Given this list of marker genes TIMP3, MCL1, AKT1, BAG1, FAIM, here is a description of the gene set: Human Gene Set: LAU_APOPTOSIS_CDKN2A_DN Genes down-regulated by UV-irradiation in cervical cancer cells after knockdown of CDKN2A. from publication Lau WM, Ho TH, Hui KM (PMID 17369842) species: Homo sapiens p16(INK4A) (p16) has been suggested to be an early biomarker for the detection of cervical cancer. However, its functional role in cervical cancer is not well characterized. In this study, we reported the consistent and significant upregulation of p16 in cervical cancer tissues when compared to both matched non-tumourous tissues of the same patient and normal cervical tissues from non-cancer patients. We have employed p16 small interfering RNA (siRNA) to dissect the role of p16 in cervical carcinogenesis. Although the silencing of p16 was accompanied by the upregulation of p53, p21 and RB in the p16 siRNA-transfected cells, no significant effect on cell cycle progression was observed. When the p16 siRNA-silenced cells were subjected to DNA damage stress including ultraviolet-irradiation and cisplatin treatments, a significantly higher percentage of apoptotic cells could be observed in the p16-siRNA silenced cells compared to control siRNA-treated cells. Moreover, induction of apoptosis was associated with the activation of p53 through phosphorylation, and this process, when studied by gene profiling experiments, involved both the intrinsic and extrinsic apoptotic pathways. The observation that silencing of p16 expression augments DNA damage-induced apoptosis in cervical cancer cells offers alternative strategies for anti-cancer therapies for human cervical cancer.